Given this list of marker genes Gfpt2, Pfkl, Gck, Nfe2l1, Hk1, Pfkp, Pfkm, Fbp2, Hk2, Gpi1, Hk3, Gfpt1, Gnpda1, Fbp1, Taldo1, Mpi, here is a description of the gene set: The chemical reactions and pathways involving fructose 6-phosphate, also known as F6P. The D-enantiomer is an important intermediate in glycolysis, gluconeogenesis, and fructose metabolism. Mouse Gene Set: GOBP_FRUCTOSE_6_PHOSPHATE_METABOLIC_PROCESS studied in species Mus musculus